Given this list of marker genes PEX6, MAG, POLR3A, AP4E1, ATXN8OS, RAB3GAP2, MARS2 (methionyl-tRNA synthetase 2, mitochondrial), GLRX5, AP4M1, AP4S1, TDP1, SPART, AP4B1, SPG7, GJB1, PNPT1, GBA2, ATP2B3, ALDH18A1, VAMP1, MAPT, PRNP, ENSG00000288330, ALS2, ERLIN2, AFG3L2, here is a description of the gene set: Human Gene Set: HP_SPASTIC_DYSARTHRIA Spastic dysarthria A type of dysarthria related to bilateral damage of the upper motor neuron tracts of the pyramidal and extra- pyramidal tracts. Speech of affected individuals is slow, effortful, and has a harsh vocal quality. studied in species Homo sapiens